The following is a description of a gene set: The commitment of cells to specific cardiac muscle cell fates and their capacity to differentiate into cardiac muscle cells. Cardiac muscle cells are striated muscle cells that are responsible for heart contraction. Human Gene Set: GOBP_CARDIAC_MUSCLE_CELL_FATE_COMMITMENT studied in species Homo sapiens, and this is the list of marker genes: NKX2-5 (NCBI Gene Id 1482), WT1, TBX3, WNT3A, MIR19B1, ACVR1, TBX5, TBX18